Given this list of marker genes GPS2, VASH2, TEX264, GALNT6 (polypeptide N-acetylgalactosaminyltransferase 6), RNF181, TSPAN32, PRP4K, PTPRE, CTSC, ZNF260, NCF1 (NCBI Gene Id 653844), KLHL17, KCTD14, C2orf68, CD79B, CLIP1, NUDT6, GDPGP1, CRB3, NPC1, LSP1, B4GALT5, PDE8B, SLC46A3, ARSB, SMPD1, CRADD, HVCN1, PISD, INCA1, HSD17B4, FICD, ALG2, ZSCAN26, IPCEF1 (NCBI Gene Id 26034), NFRKB, SUPT20H (NCBI Gene Id 55578), YIPF6, SLC37A4 (NCBI Gene Id 84965), MCCC1, PTPN6, CASP8, PARD6G, NADK, GPX1, RPS11, UBE3B, CHIC1, AMER1, FAM120B, PIK3CG, CHMP1B, GRN (NCBI Gene Id 2896), BCAS3, SAMHD1, CRLF3, CIZ1, SPAG9, LUC7L2, GIMAP1, SLC35B3, CDK16, SPNS1, WBP1L, CACFD1, RPS21, CISD3, BTD, CD22, ATE1, CALCOCO1, SIDT2, IP6K1, TMEM229B, CPSF7, STAT6, DAZAP2, BAZ2B, TRIM7, PCIF1, GLT8D1, PIK3R4, TMC6, FLI1, IQGAP1, PARP14, CAST, ZCCHC2, RELA, MED12, SIPA1, CNTD1 (NCBI Gene Id 124817), USF3, LTB, ACP2, CNR2, DENND6B, GNG2, PHF7, PPCS, ENTREP3, ZYG11B, CPM, CD276, SIPA1L3, RFK, LIAT1, BCLAF1, WFS1, ANKZF1, IQSEC1, PIGX, BTBD1, ETFRF1, AIDA, TBC1D20 (TBC1 domain family member 20), SPICE1, TMEM181, FNBP4, C1orf54, PIP4P2 (phosphatidylinositol-4,5-bisphosphate 4-phosphatase 2), MXD4, C1orf198, GRAP2, FCRL1, LPGAT1, CD84, MMS19 (NCBI Gene Id 64210), DHRS7, IRF4, SLC2A6, ABCC5, NFKB1, PATJ, RGP1, COL6A5, ZNF266, CD47, METTL3, NUAK2, GRAMD2B, EFCAB9, TVP23B, PIAS3, IMMP2L, PLGRKT, SLC9A8, INPP5F, PLCG1, MDP1, WDFY4, HSH2D, LDB1, GLO1, MFSD3, LATS2, TRIM11, CFLAR, UNKL, GOLGA5, ALG1, PBXIP1, TNFRSF13B, KMO, RBL2, MIEF2, SUN1, RAB37, ZNF398, GRAP, BAZ2A, ENTPD4, CLCN5, ZNF808, NFKB2, DNAJB14, ZDHHC13, INPP4B (NCBI Gene Id 8821), RHOF, TMEM9B, REEP5, SPTBN1, FAM193B, LYN, TM9SF2, DIP2B (NCBI Gene Id 57609), SLCO5A1, UBA7, KCTD6, EP300, PRSS46P, KMT2D, AZI2, SLC4A11, TMEM115, PAN2, NUCB2, RSBN1, SDF4, HLA-DOA, here is a description of the gene set: Effects of SOCS3 on the transcriptional response of bone marrow-derived macrophages to IL-6. Fetal liver cells from SOCS3+/+ or SOCS3-/- embryos were used to reconstitute recipient mice. Donor derived bone marrow from these mice was differentiated to macrophages. Macrophages were either unstimulated, or stimulated for 100 or 400 minutes with 10 ng/ml IL-6. Human Gene Set: GSE411_100MIN_VS_400MIN_IL6_STIM_SOCS3_KO_MACROPHAGE_DN studied in species Homo sapiens Genes down-regulated in macrophages with SOCS3 knockout treated by IL6: 100min versus 400min. from publication Lang R, Pauleau AL, Parganas E, Takahashi Y, Mages J, Ihle JN, Rutschman R, Murray PJ (PMID 12754506)